The following is a description of a gene set: Human Gene Set: DESCARTES_FETAL_CEREBELLUM_UNIPOLAR_BRUSH_CELLS from publication Cao J, O'Day DR, Pliner HA, Kingsley PD, Deng M, Daza RM, Zager MA, Aldinger KA, Blecher-Gonen R, Zhang F, Spielmann M, Palis J, Doherty D, Steemers FJ, Glass IA, Trapnell C, Shendure J (PMID 33184181) The gene expression program underlying the specification of human cell types is of fundamental interest. The study authors generated human cell atlases of gene expression and chromatin accessibility in fetal tissues. For gene expression, the study authors applied three-level combinatorial indexing to >110 samples representing 15 organs, ultimately profiling ~4 million single cells. The study authors leveraged the literature and other atlases to identify and annotate hundreds of cell types and subtypes, both within and across tissues. Our analyses focused on organ-specific specializations of broadly distributed cell types (such as blood, endothelial, and epithelial), sites of fetal erythropoiesis (which notably included the adrenal gland), and integration with mouse developmental atlases (such as conserved specification of blood cells). These data represent a rich resource for the exploration of in vivo human gene expression in diverse tissues and cell types. studied in species Homo sapiens Marker genes curated from the annotated cluster as represented in the Descartes Human Gene Expression During Development database., and this is the list of marker genes: OTX2-AS1, LINC01885, CNGB1, RPGRIP1, MARK2P19, OTX2, ENSG00000228033, MID1 (midline 1), SSBP3P1, HTR5A, QRFPR, LINC02932, TMEM237, SLC27A6, LECT2, LINC02032, PCARE, CHST9, ENSG00000250378, RPS3P6 (NCBI Gene Id 650160), EOMES, ARSJ, TPBG (trophoblast glycoprotein), RSPO2, ENSG00000259737, CHRM5, COL13A1, RPH3A, LMX1A, FBXL21P, HTR5A-AS1, CDH9, DYNC1I1